Given this list of marker genes ZNF674, HRH2, RHOJ, DEPDC5, GFRA4, CD164, FOXP4, GLYAT, PI3, FBXL20, GPT2, DMRT1, CNEP1R1, CTDSPL, MTFMT, EXOSC6, CPSF7, YWHAQ, CDC42EP1, GFAP, PCBD2, HOOK3, NOS1, NOVA2, MDM4, PYGO1, GNPNAT1, KCNJ6, CSF3R, CIC, DTX4, MUCL3, LYZL2, SP8, PAPOLG, EOGT, SLC2A4, SPI1, FAM72B, EXPH5, GLG1, LYN, CCDC28A-AS1, DNAJC8, APELA, ZNF544, CCL22, MIP, SLC6A11, HUNK, MTCL2, NFIC, SYBU, POLR2D (NCBI Gene Id 9393), SCGN, FIBCD1, COL27A1, MEFV, GPR83, APOBEC3F, RRP15, BCKDHB, ACADSB, CTSW, PDE7A (NCBI Gene Id 5150), ASPG, ZNF432, TMEM239, NHEJ1, ZNF554, COL11A2, TRAF3IP2, NTN1, CDK8, SV2C, MASP1, BORCS8 (NCBI Gene Id 729991), UPK2, PRICKLE3, ANKS4B, ARGFX, ACKR2, CORO2B, CYP1A2, PIGK, SLC35E2A, RPL15, SHISA6, CYP20A1, CCL28, ODAPH, VIRMA, ITLN1, VPS25, TMTC1, RBMS2, EEF2K, F2RL2, SHISA7, GNL3L (NCBI Gene Id 54552), SLC35F6, GFOD2, FCAR, MS4A10, EFCAB2, RAB37, MS4A1, DVL1 (dishevelled segment polarity protein 1), RIT1, SULT1E1, GAB2, SKA1, H6PD, CEBPZOS, SCAI, ESYT1, PPP1R11, VAMP1, NOL9, ZNF655 (zinc finger protein 655), CBX5, EBAG9, CHTF8 (chromosome transmission fidelity factor 8), TMEM132E, CDH1, PLEKHA5, PARP9, KCNIP1, ZDHHC15, TIAM1-AS1 (NCBI Gene Id 150051), ZNF286B, PACS1, ATXN1, FNIP1, RALB, PLCXD1, CCNT1, MPIG6B, SH3BP2, SETD7, BMAL2, ZNF385A, HCFC1, RAD51B, MTX3, IFI6, RIMS3 (regulating synaptic membrane exocytosis 3), IGF2BP1, ATP1B4, RNF24, NCEH1, ORAI2 (NCBI Gene Id 84917), CORO1C, HSPB7, ZNF814, ERBB3 (erb-b2 receptor tyrosine kinase 3), FAM72A, CALCR, TCTN2, PRR23C, ARNT2, PSMB2 (NCBI Gene Id 5690), TMEM63C, DDX6, GCFC2, ZNF490, FRMD5, DERL1, ABCG4, LRRC51, RAB21, RNF8, APOL6, TMEM14B, LYZL1, SAMD4A, PARD6B (par-6 family cell polarity regulator beta), PRRG1, ATP7B, CDADC1, VPS13B, SUSD5, DAB2IP, MYO10, RPRD1B, CGNL1, ELK1 (ETS transcription factor ELK1), CASP10, NMNAT2, RRP7A, KDM4E, NSL1, MARK4, ZFHX2, MAML1, CYP2B6, ARID2, IKZF3, TMEM265, NDST1, SNAPC3, FBXL18, GDI1, PNMA2, FOXK1, DYDC2, RBM19, SHOX, LHPP, CASTOR2, CHN2, OSBPL1A, SYNGR1, KLF7, MAPK13, PRND, GLS, C7orf25, FUS, GNAT1, MAVS, SYP, LRPAP1, PHACTR4, STX5, IRGQ, CLSPN, ZNF793, PYCR3, SBSPON, MRPS2, PGBD1 (piggyBac transposable element derived 1), NID1, here is a description of the gene set: species: Homo sapiens Genes predicted to be targets of miRBase v22 microRNA hsa-miR-6780a-5p in miRDB v6.0 with MirTarget v4 prediction scores > 80 (high confidence targets). Human Gene Set: MIR6780A_5P from publication Chen Y, Wang X (PMID 31504780)